Given this list of marker genes Il33, Trem2, Ndp, Mapk1, Ptk2, Mapk3, Il34, Gba1, Clu, Csf1, Cx3cl1, Csf1r, here is a description of the gene set: studied in species Mus musculus Mouse Gene Set: GOBP_MACROPHAGE_PROLIFERATION The expansion of a macrophage population by cell division.